The following is a description of a gene set: studied in species Homo sapiens Human Gene Set: GOBP_POSITIVE_REGULATION_OF_EPITHELIAL_CELL_APOPTOTIC_PROCESS Any process that activates or increases the frequency, rate or extent of epithelial cell apoptotic process., and this is the list of marker genes: PIAS4 (protein inhibitor of activated STAT 4), ISL1, MIR675, MIR4516, PLA2R1, SAV1, GSN, JAK2, CARM1, PLA2G1B, CAPN10, SFRP4 (NCBI Gene Id 6424), IL6, BAX, EIF2S1, USP17L24, WNT11, HMOX1, STK4, TIA1, HDAC3